Given this list of marker genes SCAMP3, DDX18, ATP1B3, MRPS27, SNRPD1, HDDC2, GGCT, CAPZA2, SUB1, PALLD, FASLG, TRMT1, MATK, IMMT, ACSL3, UTP20, COPS8, EXOC3, RRP7A, NMT1, CFLAR, UQCR11, EIF4E2, RIPK2, ISG20L2, CD28, URB2, RHOG (ras homolog family member G), SQLE, NEFH (NCBI Gene Id 4744), TMCO1 (transmembrane and coiled-coil domains 1), CETN3, BRD8, TM9SF1, ATXN1, NFIL3, NUP188, TRIAP1, UBA2, ZW10, ZNF75D, EIF4A1, DIMT1, GTF2E2, CPOX, NELFE, HIVEP2, JPT2, PA2G4, CCL20, IDH3A, DNAJC7, NKRF, AGO2 (NCBI Gene Id 286109), CHSY1, LAMA2, OAT, KPNB1, TXN, MAPKAPK3, UBE2G2, PSMD1, MTX2, MARS1, MIF, ABCE1, PARG, PEA15, HPS5 (NCBI Gene Id 246309), FUS, PSMB5, GTPBP6, SNAPC4, BET1, PDS5A, HMGN4 (NCBI Gene Id 10473), NT5E, TNFRSF9, NUP88, WDR47, RRAS2, HSPBP1, GPM6B, PPT1, TEX261, PWP1, NDEL1, MKLN1, PSMB6, TXNL4A, EIF1AX, SLC25A5, GBE1, NME1, HCCS, UTP18, NPM3 (nucleophosmin/nucleoplasmin 3), LCP2, IDI1, ADARB1, UTP14C, CCN6, TAF1B, RPA2, PDIA3, SRM, TIMM17A, LPL, UNG, TRA2B, TNF, GAD1, METTL1, IL1R1, PSMD7, CD226, TOR1B, PPP2CA, WNK1, IL12RB2, PNP, DUSP5, NFATC1, GZMB, MRPS12 (NCBI Gene Id 6183), HNRNPF, NCKAP1, NHP2, SPTSSA, PDCD2, FXN, NUP160, MTA1, PGK1, MAPRE2, HYOU1, AATF, PSMB3, MAMLD1, SRGN, TUBA1B, NOP56, HNRNPDL, LDHA, CDK2AP1, RANBP2, TXNDC9, LYSET, ZNF195, HPRT1, HNRNPA3, PDIA5, VDAC3, LTBP4 (NCBI Gene Id 8425), RCAN1, GNL2, POP4, GHITM, OSGEP, PMS1, LIG4, PGGT1B, ADO, NSMAF, GTF2F2, SLC16A7, CPSF4, SUCLA2, SLC29A1, CD9, TCTN3, LPCAT1, RBM6, ELMO1, HNRNPC, DBI, UBE2D1, EIF4G3, VCP, GNG5, SSRP1, RCN1, PKM, HAUS7, R3HDM1, PPP1CC, SNHG3, FRMD4B, IL1B, ZBTB24, MGA, ENO1, FKBP4, POLR2G, LAMP3, CCDC86 (NCBI Gene Id 79080), DDX42, CDK4, ZNF200, NUP42, here is a description of the gene set: Genes up-regulated in activated T cells: CD4 versus Va24- NKT. Human Gene Set: GSE28726_ACT_CD4_TCELL_VS_ACT_VA24NEG_NKTCELL_UP from publication Constantinides MG, Picard D, Savage AK, Bendelac A (PMID 21632718) Microarray analysis was performed to determine the transcriptional profiles of NKT, CD1d-aGC+ Va24-, and CD4 T cells. species: Homo sapiens